Given this list of marker genes STUB1, ITGB1 (NCBI Gene Id 3688), PPP1CC (NCBI Gene Id 5501), USP9X, TGFBR2, SKI (SKI proto-oncogene), MTMR4, TFDP2, MEN1, ARHGEF18, ZFYVE9, TGFB3, CDK9, PPM1A (NCBI Gene Id 5494), RBL1, LTBP1, SKIL, CDKN2B, PPP1CB, UBA52, LTBP4, RHOA, SNW1, TRIM33, SMURF1, TGFB2, COL1A2, ITGB5, CGN, RPS27A, TGIF1, PMEPA1, SMAD7, PRKCZ, PARP1, UBE2D1, UCHL5, F11R, TGFB1, MAPK3, BAMBI, ITGB6 (NCBI Gene Id 3694), SMURF2, ITGB8, UBC, CCNC, CDK8, SERPINE1 (NCBI Gene Id 5054), FURIN, FBN1, RNF111, HDAC1, PARD3, SMAD4, SMAD2, CBL, TFDP1, ATP1B4, TGFBR3, NEDD4L, CCNT1, ITGAV, FKBP1A (FKBP prolyl isomerase 1A), STRAP, WWTR1, LTBP3, NCOR2, JUNB, TGIF2, ITGB3, CCNK, YBX1, E2F4, XPO1, MYC (MYC proto-oncogene, bHLH transcription factor), SP1, MAPK1, UBE2M, STAT1, LTBP2, NCOR1, ITGA8, PPP1CA, PPP1R15A, UBE2D3 (ubiquitin conjugating enzyme E2 D3), CCNT2, PARD6A, NEDD8, UBB, EP300, USP15, SMAD3, TGFBR1, E2F5, here is a description of the gene set: Human Gene Set: REACTOME_SIGNALING_BY_TGF_BETA_RECEPTOR_COMPLEX species: Homo sapiens Signaling by TGF-beta Receptor Complex